The following is a description of a gene set: Here, we show that ectopic expression of the catalytic subunit of mouse telomerase (mTert) confers a growth advantage to primary murine embryonic fibroblasts (MEFs), which have very long telomeres, as well as facilitates their spontaneous immortalization and increases their colony-forming capacity upon activation of oncogenes. We demonstrate that these telomere length-independent growth-promoting effects of mTert overexpression require catalytically active mTert, as well as the formation of mTert/Terc complexes. The gene expression profile of mTert-overexpressing MEFs indicates that telomerase enhances growth in these cells through the repression of growth-inhibiting genes of the transforming growth factor-beta (TGF-beta) signaling network. We functionally validate this result by showing that mTert abrogates the growth-inhibitory effect of TGF-beta in MEFs, thus demonstrating that telomerase increments the proliferative potential of primary mouse embryonic fibroblasts by targeting the TGF-beta pathway. Genes down-regulated in MEF cells (embryonic fibroblasts) with TERT knockout, after expression of the gene off a retroviral vector. studied in species Mus musculus from publication Geserick C, Tejera A, González-Suárez E, Klatt P, Blasco MA (PMID 16501597) Mouse Gene Set: GESERICK_TERT_TARGETS_DN, and this is the list of marker genes: Errfi1, Siah2, Zfp36, Eln, Klf9, Gadd45g, Klf10, Junb, Ier3, Egr2, Hbegf, Klf4, Nfil3, Btg2, Nr4a1, Bhlhe40 (basic helix-loop-helix family, member e40), Hey1, Gadd45b, Nfkbiz, Dusp6, Fosb